The following is a description of a gene set: Genes up-regulated in prostate cancer samples. Human Gene Set: LIU_PROSTATE_CANCER_UP Prostate cancer is the most commonly diagnosed noncutaneous neoplasm and second most common cause of cancer-related mortality in western men. To investigate the mechanisms of prostate cancer development and progression, we did expression profiling of human prostate cancer and benign tissues. We show that the SOX4 is overexpressed in prostate tumor samples compared with benign tissues by microarray analysis, real-time PCR, and immunohistochemistry. We also show that SOX4 expression is highly correlated with Gleason score at the mRNA and protein level using tissue microarrays. Genes affected by SOX4 expression were also identified, including BCL10, CSF1, and NcoA4/ARA70. TLE-1 and BBC3/PUMA were identified as direct targets of SOX4. Silencing of SOX4 by small interfering RNA transfection induced apoptosis of prostate cancer cells, suggesting that SOX4 could be a therapeutic target for prostate cancer. Stable transfection of SOX4 into nontransformed prostate cells enabled colony formation in soft agar, suggesting that, in the proper cellular context, SOX4 can be a transforming oncogene. studied in species Homo sapiens from publication Liu P, Ramachandran S, Ali Seyed M, Scharer CD, Laycock N, Dalton WB, Williams H, Karanam S, Datta MW, Jaye DL, Moreno CS (PMID 16618720), and this is the list of marker genes: RAB3D, APRT, ST14, CANT1, TRIB1, CREB3L1, TRGC1, RAP1GAP, GJB1, UAP1, SLC19A1, ABCC4, PCA3, EPCAM, TRPM4, AKR1A1, CLDN8, CCNG2, TMEM161A, GDF15, GGCT, SOX4 (NCBI Gene Id 6659), DANCR, CADM1, MYO6, LYPLA1, ENTPD6, CAMKK2, SNORD60, NLE1, GUCY1A1 (NCBI Gene Id 2982), GOLM1, FNIP2, HPN, SRPRB, HOXC6, ALDH1A3, ATF6B (activating transcription factor 6 beta), PDLIM5, BCAM, C9orf152, ELK1, LRIG1, SAMD5, GALNT7, REPS2, ENTPD5, PPP1R14B, RAB17, MTHFD2, ICA1-AS1, PTP4A3, TP53INP1, TBC1D4, H2AC25, MARCKSL1, BZW2, MAP2K6, TRIM68, RPL22L1 (ribosomal protein L22 like 1), OR51E2, ENSG00000254531 (NCBI Gene Id 90024), PDIA5, PPP1R9A, AMACR, RNF41, TP53, FARP1 (NCBI Gene Id 10160), PYCR1, ARHGEF26, TSPAN13, SERP1, HID1, GADD45G, FBP1, DNAH5, SIM2, EDRF1, CALR, NME2, SOX9, TMTC4, GMDS, PPP3CA, EIF4A1, CCL3, DNPH1, PPM1E, SLC35B2, GLYATL1, EIF2AK1, BEND4, SH3RF1, IMPA1, VSTM2L, SEL1L (NCBI Gene Id 6400), PTRHD1, ECI2, SLC43A1